The following is a description of a gene set: Genes up-regulated in erythroid progenitor cells isolated from bone marrow of patients with Diamond-Blackfan anemia (DBA) and mutated RPS19. studied in species Homo sapiens Human Gene Set: GAZDA_DIAMOND_BLACKFAN_ANEMIA_ERYTHROID_UP Diamond-Blackfan anemia (DBA) is a broad developmental disease characterized by anemia, bone marrow (BM) erythroblastopenia, and an increased incidence of malignancy. Mutations in ribosomal protein gene S19 (RPS19) are found in approximately 25% of DBA patients; however, the role of RPS19 in the pathogenesis of DBA remains unknown. Using global gene expression analysis, we compared highly purified multipotential, erythroid, and myeloid BM progenitors from RPS19 mutated and control individuals. We found several ribosomal protein genes downregulated in all DBA progenitors. Apoptosis genes, such as TNFRSF10B and FAS, transcriptional control genes, including the erythropoietic transcription factor MYB (encoding c-myb), and translational genes were greatly dysregulated, mostly in diseased erythroid cells. Cancer-related genes, including RAS family oncogenes and tumor suppressor genes, were significantly dysregulated in all diseased progenitors. In addition, our results provide evidence that RPS19 mutations lead to codownregulation of multiple ribosomal protein genes, as well as downregulation of genes involved in translation in DBA cells. In conclusion, the altered expression of cancer-related genes suggests a molecular basis for malignancy in DBA. Downregulation of c-myb expression, which causes complete failure of fetal liver erythropoiesis in knockout mice, suggests a link between RPS19 mutations and reduced erythropoiesis in DBA. from publication Gazda HT, Kho AT, Sanoudou D, Zaucha JM, Kohane IS, Sieff CA, Beggs AH (PMID 16741228), and this is the list of marker genes: CSF1, LIMK2, HNRNPR, SCRN1, PDK3, AEN, PRKX, LEPR, TEFM, FAS, SOS1, SPHK2 (NCBI Gene Id 56848), TRIM38, NUP62CL, DDB2, NUFIP1, TNFRSF10B, DPY19L1, DRAM1, ATP6V1B2, SNRNP70, UTP6, SESN1, SEPHS2, NSF, DENND2D